Given this list of marker genes Rpia, Mri1, Gpi1, Mpi, Tpi1, Hyi, here is a description of the gene set: Mouse Gene Set: GOMF_INTRAMOLECULAR_OXIDOREDUCTASE_ACTIVITY_INTERCONVERTING_ALDOSES_AND_KETOSES species: Mus musculus Catalysis of an oxidation-reduction (redox) reaction in which the hydrogen donor and acceptor, which is an aldose or a ketose, are the same molecule, and no oxidized product appears.